Given this list of marker genes EMCN, CD9, FN1, CD63, RPS27A, TPT1, CNN3, UBE2D3, TIMP3, DOCK4, HSP90B1, TXNIP, KALRN, EGFL7, CEACAM1, SH3BP5, FTH1, RPS12, RPL19, ARHGAP29, B2M, CANX, ARHGAP26, TMSB4X, HSP90AB1, NCL, UTRN, SPTBN1, RPS14, CAVIN2, HNRNPDL, MYL6, MYL12A, RPL13A, RPL7, VIM, HLA-B, GPM6A, IGFBP5, RPL5, NAMPT, RPL4, ADAMTS9, ADGRF5, ENG, ADGRL4, HLA-DRB1, MYL12B, GAPDH, PLPP3, RHOA, TCIM, PTPRB, TCF4, DDX5, JAK1, DNASE1L3, RPS23, QKI, AKT3, RBMS1, ZEB1, TFPI, IGFBP7 (NCBI Gene Id 3490), ASAP1, RPL3, PECAM1, APP, TLL1, RPLP2, RBMS3, PBX1, ACTG1, RPLP0, ZNF385D, PSMA7, EIF1, YWHAB, NPM1, H3-3B, EEF1A1, FBXL7 (NCBI Gene Id 23194), LDB2, RPLP1, PLAT, RPL8, PPFIBP1, MEIS2, RPS16, CD74, MEF2A, ST6GALNAC3, TMSB10, FLT1, HNRNPA2B1, RPL10, PRDX1, RPL31, CD59, EPAS1, RPS19, RPS8, IL6ST, TMTC2, RASAL2, RACK1, RPL13, SASH1, HLA-E, FTL (NCBI Gene Id 93315), RPL18, MT2A, AHNAK, RPS2, PTTG1IP, MIR99AHG, TGM2, HLA-DRA, IFITM3, TGFBR2, RPS6, ID1, PTMA, PABPC1, PTPRM, XRCC5, here is a description of the gene set: from publication Lake BB, Chen S, Hoshi M, Plongthongkum N, Salamon D, Knoten A, Vijayan A, Venkatesh R, Kim EH, Gao D, Gaut J, Zhang K, Jain S (PMID 31249312) Human Gene Set: LAKE_ADULT_KIDNEY_C23_ENDOTHELIAL_CELLS_AVR studied in species Homo sapiens